The following is a description of a gene set: studied in species Homo sapiens Human Gene Set: GOBP_REGULATION_OF_PENTOSE_PHOSPHATE_SHUNT Any process that modulates the frequency, rate or extent of the pentose-phosphate shunt, the process in which glucose is oxidized, coupled to NADPH synthesis., and this is the list of marker genes: TP53 (NCBI Gene Id 7157), MTOR, TIGAR, MLST8, RPTOR, ALDOB